Given this list of marker genes Apc2, Fbxl16, Psmd2, Hamp, Cpb2, Egfr, Ube2n, Cd81, Zdhhc2, Fbxo48, Psmd10, Trpc4ap, Pramel31, Rnf26, Ube3c, App, Tmem132a, Trib3, Chmp3, Psmb10, Cblb, Gtsf1, Chmp1b2, Nsf, Ube2h, Lonp1, Nkd1, Dcaf12, Ufsp2, Kcne2, Cenatac, Rmnd5b, Cdkn1b, Fbxo22, Derl1, Klhl25, Nploc4 (NCBI Gene Id 276977), Rnf111, Agbl4, Adam9, Znrf4, Mir196b, Amfr, Tlk2, Hectd3, Fbxo7, Nedd4 (NCBI Gene Id 639396), Slc9a1, Gtpbp1, Anapc5 (NCBI Gene Id 67965), Tmem67, Apoe, Zfp418, Ext1, Styx-ps, Oxa1l, Notch1, Agtpbp1, Mme, Cnot6l, Psmd1, Wfs1, Zpr1, Erlin1, Sec61b, Rnf133, Tnrc6a (NCBI Gene Id 76695), Psmb2, Pkd1 (polycystin 1, transient receptor potential channel interacting), Cd2ap, Slfn8, Trim67 (NCBI Gene Id 330863), Rnf13, Nkd2, Arih1, Hspa1a, Caprin1, Psmc1, Foxl2 (forkhead box L2), Pygm, Ecpas, Rchy1, Fbxw7, Sufu, Erap1, Pramel33, Hyal3, Cbfa2t3, Hexb, Gid8, Trib2, Dtx3l, Socs5, Oaz3, Psme3, Ptbp1, Sharpin, Gm11690, Anapc13, Ern1, Cdkn2a, Dlgap1, Ltn1, Sdf2l1, Ubxn8 (UBX domain protein 8), Slc17a9, 4930486L24Rik, Gclc (NCBI Gene Id 28039), Abhd13, Slc6a7, Cnot7, Gspt2, Psmd3, Calcr, Wipi2, Afg3l2, Efna1, Nop53, Dpp3, Pramel41, Pcbp2, Khsrp, Psap, Nupr1, Samd9l, Yme1l1, Cpeb3, Nudt16, Rnf187, Samd4, Fap, Stx5a, Exosc3, Ago3, Fbxl4, Psmc4, Dhx9, Rnaseh2b, Atg4b, Uba52, Snhg15, Vps4a, Bfar, Disc1, Pnrc1, Mirlet7c-1, N4bp1, Becn1, Ctsd, Rab12, Plekhn1, Ttc3, Fbxw4, Tmub2 (transmembrane and ubiquitin-like domain containing 2), Chmp7, Prr5l, Lsm14b, Sgsm3, Cnot8, Wnt5a, Grsf1, Rc3h1, Klhl42, Herpud1, Lnx1, Bag6 (BCL2-associated athanogene 6), Foxo1, Prpf19, Ivns1abp, Agap2, Atraid, Pramel6 (PRAME like 6), Cln3, Ldc1, Nrg1, Ubxn11, Fbxl9, Afg2b, Nrdc, Rnf11, Ppp1r3b, Mir144, Ubqln4, Nbas, Nfe2l2 (NCBI Gene Id 98874), A1cf, Tnf, Arrb1, Ubl4a, Ift80 (intraflagellar transport 80), Ascc2, Gna12, Tmem9, Sgta, Calr, Csde1, Hace1 (NCBI Gene Id 73291), Rnf121, Grn, Tent5d, Hipk2, Zar1, Pop1, Pygb, Svip, Rnf126, Slc6a17, Mgat3, Cdh1, Nedd4l, Rbm38, Znrf1, Dicer1, Ppp1cb, Dab2ip, Upf2, Ern2, Psmc3, Man1c1, Gsk3b, Ubxn2b, Apex1, Rnf6 (ring finger protein (C3H2C3 type) 6), Sumo2, Nr1d1, Skp1, Kbtbd12 (NCBI Gene Id 74589), Uba6, Fxr1, Apoc2, Mtrex, Lipa, Uchl1, Dnajc10, Ppp1r3e, Pramel25, Rmnd5a, Wwp2, Lsm7, Rffl, Ikbke, Rhbdd3, Tgfb1, Spsb3, Nsfl1c, Nub1, Lyplal1, Gm12610, Rad23b, Eri1, Ccin, Uvrag, Mettl1, Cyp51, Sgsh, Rpl11, Csdc2, Kctd17, Setmar, Calr3, Nhlrc3, Dvl1, Naf1, Adam8, Man1b1, Exosc6 (exosome component 6), Asb5, Nemf, Axin1, Kbtbd3, Mmp12, Tent4b (NCBI Gene Id 70570), Pramel37, Traf7, Fem1b (fem 1 homolog b), Hmgb1 (NCBI Gene Id 15289), Pramel13, Cop1, Cpa1, Herc4, Ctss (NCBI Gene Id 13040), Snx1, Fbxl22, Csnk2b, Usp7, Ube2l6, Trim31, Rdx, Fastkd3, Plk3, Wdr45, Abhd12, Anapc16, Psmc6, Laptm4b, Vps25, Ptpn23, Pramel55, Ythdf1, Malt1, Tbl1x, Rnf185, Pramel26, Trim45, Ube3b, Akirin2, Zfp598 (NCBI Gene Id 213753), Cdk5, Gata5, Atp13a2 (NCBI Gene Id 74772), Tent5a, Anapc10, Phkb, Cacul1, Cpn1, Gns, Arel1, Ybx2, Uba1y, Spopfm3, Edc4, Fgf2, Pramel42, Selenos, Azin2, Psme3ip1, Pcbp4, Clock, Ddi1, Cdk5rap3, Fbxo45, Ankrd9, Ddrgk1, Spop, Acr, Paip1, Fbxl18, Armc8, Sox17, Vegfa, Ddit3, Erlin2, Tspan5, St14, Rnf148, Mmp9, Etf1, Abca2, Vgll4, Gba1 (NCBI Gene Id 14466), Atg7, Man1a2, Isg20, Zfp36l3, Crbn, Igf2bp1, Psmb1, Boll, Cdc26, Keap1, Folh1, Zfp36, Zfp36l1, Fam83d, Pisd, Gga3, Idua, Pgpep1, E2f1, Ubxn7, Cul9 (cullin 9), Pdcl3, Pias4, Mmp2, Dnase1, Nudt16l1, Adrb1, Herc2, Klhdc10, Rybp, Trim72, Ube2a, Fam76b, Araf, Kctd5, Grin2c, Crebrf, Fbxw8, Fastkd1, Ceacam2, Wnt10b, Ube2j2, Det1, Pkp1, Rnf25, Snf8, Traf5, Timp1, Rnft1, Klhdc2, Lats1, Sqstm1, Siah1b, Trim32, Slc11a1, Tardbp, Trip12, Kctd10, Ssb, Exosc4, Rnaseh2a, Spopfm2, Dnajb12, Rbm24, Nqo1, Il17a, Derl3, Mkrn2, Trp53inp2, Map1a (microtubule-associated protein 1 A), Dtl, Psmb11, Lyve1, Ube2z, Scgb1a1, Sirt2, Psme4, Tmtc3, Isg15, Pcsk9, Ctsz, Rbm46, Serpinb1b, Pcid2, Oog1, Pramel11, Klhdc1 (NCBI Gene Id 271005), Oaz2, Cops3, Dis3l, Zc3h4, Gigyf2, Ripk1, Nedd8, Usp19, Ythdf3, Phb1, Aifm1, Aoah, Gpx1, Exosc5, Tob1, Smg8, Trim21, Csnk2a2, Klhl20, Cul4b, Marchf2, Kctd13, Mmp3, Ubqln2, Magoh, Usp26, Ap5z1, Senp1, Fbxl17, Trim28, Cln8, Tut4, Bag2, Ube4b, Ctsk, Anapc15, Zhx2, Ube2r2, Fastkd5, Dnajb2, Sh3rf2 (SH3 domain containing ring finger 2), Skic3, Adra1b, Bbs7, Tmem168, Nanos2, Aqp11, Asb1, Dcp1b, Ubxn4, Pramel48, Zc3h18, Casc3, Trnt1, Axin2, Rbm8a2, Ubd, Herc3, Smarcc1, Gdnf, Pramel38, Arrdc4, Psme1, Bnip3l, Lamp2, Pramel1, Siah3, Trim26, Lnpep, Sco1, Znrf3, Fbxo27, Enc1, Marchf7, Zer1, Klhl35, Anapc11, Os9, Arih2, Pnldc1, Rhbdd1, Snx3 (NCBI Gene Id 54198, sorting nexin 3), Psmd4, Cnot9, Dnd1, Clpp, Fxr2, Tdpoz4, Patl2, Zc3h12d, Snx5, Mmp14, Trim30a (tripartite motif-containing 30A), Snd1, Ubr2, Fbxo2, Ddx49, Rnps1, Gabarapl1, Qki, Serpine2, Nudt12, Rnf168, Pja1, Paqr3, Fyn, Spsb1, Arrb2, Gipc1, Mettl3, Sh3rf3, Klhl21, Neu2, Glmn, Dxo, Ins2, Uhrf1, Aurka, Trip4, Smurf1, Atg5, Trex2, Rnf7l, Pfkm, Klhl11, Pramel35, Psmd7, Rab7, Psma5, Pramel30, Stt3b (STT3, subunit of the oligosaccharyltransferase complex, homolog B (S. cerevisiae)), Chek2, Mmp20, Ctnnb1, Ago2, Chmp6, Asb2, Fbxl15, Atxn3, Fbxl12, Usp9x, Ipp, Pappa, Anxa2, Ube2k, Egf, Ctsj, Septin3, Pja2, Tdpoz2, Chmp4c, Rnf144b, Psmc5, Dda1, Ric1, Tut1, Rgp1, Ube2s, Dcaf1, Ctsh, Plaa, Spsb2, Uchl5, Sirt6, Stub1, Dcps, Rexo4, Klhl12, Il1b, Rnf149, Apc, Pnpt1, Oaz1, Nbdy, Pramel44, Ccar2, Azin1, Gzmb, Ankzf1, Psmb9, Pabir1, Ctsc, Edem2, Epha4, Trim9, Ascc3, Patl1, Ubr4, Tmem199 (NCBI Gene Id 97763), Fastkd2, Tent2, Hyal2, Apobec1, Wdr82, Dhx36, Ube2v2, Rhbdf1, Rnf166, Ecscr, Foxred2, Osbpl7, Xbp1, Hamp2, Nell1 (NEL-like 1), Trem2, Ins1, Ube2j1, Sec22b, Traf4, Sumo3, Rnf186, Ier3, Zcchc17, Casp12, Mapk8, Bnip3l-ps, Ctrb1, Rbm7, Xrn2, Rela, Ubr5, Fhit, Smad4, Tent5c, Ifng, Psmb3 (NCBI Gene Id 99155), Samd4b, Git1, Ube2l3, Chit1, Klhl23, Rnf115, Rnf216, Exog, Shh, Rbx1, L3mbtl3, Vps54, Il6, Klhl38, Usp25, Ddx5, Wdr77 (WD repeat domain 77), Fen1, Dazl, Mirlet7c-2, Plk1, Ttc5, Lin28a, Pan2, Trim39, Anapc15-ps, Ate1, Ntaq1, Grin2a, Tbx21, Btk, Oog4, Nanos1, Pum1, Rb1cc1, Dis3, Zp3r, Fbxo39, Usp44, Spsb4, Socs4, Rnf103, Lypla1, Trim38, Cul2, Pramel53, Ubl7, Hnrnpd, Ddb1, Hdac6, Hnrnpu, Cdc20b, Tspan17, Ark2c, Tcirg1, Pramel21, Fbxo44, Meioc, Rnf167, Klhl30, Slc6a8, Slfn9, Brinp1, Gpc3, Ogt, Anapc1, Cnot1, Otud7a, Slirp, Mlh1, Zc3h12a, Pramel7, Exosc8, Cirbp, Pcyox1l, Ppp1ca, Pglyrp3, Wipi1, Afg1l, Galns, Klhl41, Pnrc2, Ntan1, Psmd6, Nfe2l1, Rnf43, Hyal4, Maea, Pgm1, Cul3, Mdm2, Tbl1xr1, Uchl3, Gabarapl2, Smg5, Nccrp1, Taf9, Atg2a, Vip, Ubxn6, Timp2, Rnf123, Socs2, Wwtr1, Znrf2, Hnrnpc, Dnase2b, Ddi2, Vps36, Kctd21, Zc3hav1, Herc6, Gprasp1, Tmem129, Uba7, Upf3b (UPF3 regulator of nonsense transcripts homolog B (yeast)), Chmp4b, Pramel17, Chi3l1, Fbxw11, Fbxl20 (NCBI Gene Id 97750), Mfsd8, Ophn1, Lin28b, Tirap, Hnrnpab, Cemip, Hectd1, Dis3l2, Ctsq, Noct, Utp25, Dnase1l3, Zfp36l2, Cav1, Snx33, Tmem106b, Slfn2, Rnf125, Desi1, Naglu, Psmb8, Ang, Stab2, Notum, Ndufa13 (NADH:ubiquinone oxidoreductase subunit A13), Prkaca, Vps37d, Spata18, Tmf1, Tmem259, Lonp2 (NCBI Gene Id 66887), Ubxn10, Ngly1, Gan, Akt1, Usp13, Ccdc47, Psmb5, Ctso, Magohb, Xrn1, Cela1, Gusb, Ankib1, Ctsa, Klhdc3, Pabpc1, Hgsnat, Tbrg4, Cnot3, Oog2, Ube2dnl1, Htra2, Exosc1, Eif4a3l2, Fbxo4, Klhl29, Lrpprc, Rcn3, Trex1, Pum2, G6pc1, Mir196a-2, Trir, Hfe, Zmpste24, Abhd17c, Wdr26, Lsm4 (NCBI Gene Id 50783), Ufd1, Rnf20, Larp1, Pglyrp4, Spam1, Smg7, Filip1l, Ubb, Proca1, Pias1, Endog, Marchf6, Nrde2, Rlim, Ptk2, Dpp7, Dcst1, Kctd2, Ctsl, Fbxl2, Phka1, Secisbp2, Tnfaip3, Ang4, Atg3, Styx, Vps35, Capns1, Psmb6, Adamts13, Vps37b, Fbxw5 (F-box and WD-40 domain protein 5), Ube2u, Arrdc1, Rnf150, Lgmn, Capn10, Gfap, Pabpn1l, Dna2, Trib1, Hnrnpr (heterogeneous nuclear ribonucleoprotein R), Irak3, Hnrnpa0, Pramel22, Lsm1, Rnf130, Ube2dnl2, Exosc2, Rnasel, Pramel14, Rnf122, Ube2b, E330034G19Rik, Lyg2, Abhd17b, Hspa1b, Hyal6, Eif4enif1, Rpl23, Snx12, Chil3, Vcp (NCBI Gene Id 269523), Gspt1, Dab2, Psmf1, Asb9, Anapc4, Mettl16, Ndfip2, Piwil2, Adra2a, Cma1, Ppp1r3c (protein phosphatase 1, regulatory subunit 3C), Psmd11, Nln, Pbk, Rnf40, Park7, Bcas2, Usp38, Plg, Psma3, Piwil4, Igf2bp3, Pde12, Hsp90ab1, Rnf180 (ring finger protein 180), Rspry1, Prmt6, Mir196a-1, Prickle1, Hnf4aos, Snx25, Ubr3, Clu, Polr2g, Zfand2b, Rnf5, Gga1, Man1a, Rnf34, Pramel15, Dysf, Casp8, Hsp90aa1, Lrig2, Psma4, Rhobtb3, Smg6, Tesk1, Afg3l1, Trim40, Csnk1e, Fbxo17, Trim2, Pmp22, Fau (FAU ubiquitin like and ribosomal protein S30 fusion), Piwil1, Peli1, Rnf14, Ambra1, Rpl5, Lyset, Traf3ip2, Casp3, Pdlim2, Cts6, Pin1rt1, Commd1, Rgma (NCBI Gene Id 244058), Dnajc3, Tdpoz3, Mtpap, Sel1l2, Prkn, Chmp1a, Dennd3, Pcnp, Mtor, Ubr1, Ambp, Ncbp2, Dcp1a, Vps37a, Fem1a, Psma8, Pan3, Eif2ak3, Bcap31, Ctsw, Trim24, Dmac2, Serpinb1a, Vim, Ubc, Ccnf, Srsf1, Pramel20, Rnf7, Prep, Pramel12, Cma2, Kif16b, Npm1, Skp2, Gas5, Klhl15 (kelch-like 15), Psma2, Wdr91, Ids, Proc, Mvb12a, Calr4, Umod, Nhlrc1, Ctif, Elob, Gzmn, Igf2bp2, Rock2, Smg1, Get4, Socs7, Pramel24, Wdr45b, Kbtbd6, Birc2, Il33, Rnft2, Mir466l, Nanos3, Tdpoz9, Dffa, Klhl24, Ubap1, Aup1, Erlec1, Phkg2, Pramel36, Cela2a, Map3k1, Mus81, Mov10, Nrros, Cbl, Lamp3, Jkamp, Hecw2, Taf15, Chfr, Dnase1l2, Eloc, Ppp1r11, Fbxl13, Pramel45, Pramel29, Nudt15, Nsun4, Ttc36, Cdc16, Cdc34, Thrap3, Appbp2, Vps11, Pglyrp1, Saysd1, Psme2, Tspan15, Adcy10, Cts7, Usp8, Psma6, Rbck1, Tsg101, Uba1, Chmp2a, Eif4a3 (eukaryotic translation initiation factor 4A3), Pramel27, Mad2l2, Rps27a, Adam10, Ubqln3, Zranb1 (NCBI Gene Id 77556), H13, Pramel16, Chmp5, Rnaset2b, Dbr1, Ubap1l, Msn, Rnaseh2c, Gid4 (NCBI Gene Id 66771), Mylip, Atg2b, Hsp90b1, Chil6, Ldlr, Skic8, Ubqln5, Elavl1, Ezr, Tdpoz5, Psmb7, Kbtbd7, Slfn14, Sidt2, Rilp, Alad, Syvn1, Carhsp1, Lsm6, Manba, Mtmr2 (myotubularin related protein 2), Anks1, Mmp8, Itch, Zswim8 (zinc finger SWIM-type containing 8), Arsb, Traf2, Fbxo31, Mta1, Xpo1, Cul5, Pacsin3, Nlrp1b, Fbxl6, Lrrk2, Rnf19a, Ovgp1, Sh3glb1, Psmd8, Capn1, Oog3, Trf, Fem1c, Furin, Zyg11b, Liat1, Lyg1, Edc3, Rnf139, Pramel19, Usp28, Fbxo10, Rnf213, Cacng7, Ube2srt, Anapc7, Gpr108, Ppp1r3d, Cnot6, Snx9, Flna, Fmn2, Bag5, Cul1, Hbs1l, Tnfaip1, Snca, Csnk1a1, Fbxl14, Dact1 (dishevelled-binding antagonist of beta-catenin 1), Larp4b, Gabarap, Ptpn3, Igfbp3, Hspbp1, Faf1 (NCBI Gene Id 99976), Wwp1, Atm, Hecw1, Rad23a, Dpp4, Nsun2, Mapk15, Pramel60, C4bp, Ncbp1, Tnfsf12, Prkcg, Ppt1, Dnajb9, Klhl1, Rnf114, Smg9, Pramex1, Syncrip (synaptotagmin binding, cytoplasmic RNA interacting protein), Cblc, Cdc23, Tpp1, Vps28, Rnf4, Fto, Dkc1, Rbx1-ps, Cst3, Tollip, Chmp1b, Gtpbp2 (NCBI Gene Id 56055), Parn, Chmp2b, Glb1, Asb11, Phax, Gzmc, Mgam, Cts8, Rnf145, Cemip2, F8a, Oas2, Faf2, Ube2d2a, Irgq, Pramel43, Ago4, Bmal1, Btg2, Amer1, Wac, Nmnat1, Pml (promyelocytic leukemia), Nlrp5, Dnase2a, Mycbp2, Ercc8, Celf1, Hmmr, Elavl4, Mdm4, Sh3bgrl (SH3-binding domain glutamic acid-rich protein like), Ube3d, Tmub1, Ccdc115, Ube4a, Sh3d19, Trim13, Tut7, Klhl6, Ctsm, Oma1, Sirt1, Casp7, Pmaip1, Mapk9, Ago1 (NCBI Gene Id 286948), Alkbh5, Hexa, Midn, Spg11, Ubqlnl, Ndfip1, Usp5, Siah2, Qrich2, Edem1, Pin1, Clgn, Ybx1, Upf3a, Psma7, Plk2, Usp22, Pabpc4, Pramel18, Usp14, Ptpn1 (NCBI Gene Id 19246), Pramel40, Abhd17a, Wdr81, Rbm47, Eif2a, Sf3b3, Ube2g2, Chia1, Bnip3, Rnf217, Egln2, Pglyrp2, Gpld1, Cnot2, Trim58, Pramel46, Skic2, Sox9, Pcyox1, Mrto4 (NCBI Gene Id 69902), Csnk2a1, Blvra, Psen2, Cnot10, Vps13a, Pkp3, Cul4a, Tent4a, Rnf41, Trim71, Ube2g1, Fbxl19, Atp5if1, Lpcat1, Ythdf2, Sgms1os1, Mad2l1, Pygl, Gaa, Ecrg4, Smad3 (NCBI Gene Id 17127), Capn3, Ubac2, Spopl, Rnf170, Ufl1, Zc3h14, Hmgcr, Rbm33, Rnf144a, Rnaset2a (ribonuclease T2A), Fbxo8, Rnf8, Rock1, Socs6, Rnf19b, Ube2c, Gzma, Nicol1, Rnf215, Atg12 (NCBI Gene Id 67526), Dcaf11, Mettl14, Rbbp6, Klhl3 (NCBI Gene Id 639966), Tnrc6b, Ceacam1, Cast, Foxf2, Kbtbd8, Sh3rf1, Becn2, Dhx34, Ubqln1, Pramel5, Mapkapk2, Vps4b, Nudt16l2, Fbxo6, Lrp1, Phf20l1, Clpx, Adamts7, Bap1, Ube2w, Tgfb1i1, Il10, Ppp2cb, Exosc10, Laptm5, Nos2, Tmem126a, Pramel23, P2rx7, Rack1, Capn2, Ubxn2a, Siah1a, Adgrb1, Smurf2, Klhl28, Stam, Cdc27, Klhl5, Fastk, Pttg1ip, Neu4, Tdpoz8, Gsk3a, Cln6, Fbxo11, Edem3, Apob, Cul7 (cullin 7), Fbxo43, Ctsb, Synpo2, Pramel32, Fbxo38, Anapc2, Ubxn1, Zcchc7, Fbxl7 (NCBI Gene Id 448987), Fbh1, Csnk1d, Rbm10, Rgn, Tent5b, Lypla2, Mib1, Eif4a3l1, Timp3, Agap3, Clec16a, Myd88, Otud7b, Trim3 (NCBI Gene Id 55992), Kif14, Lsm2, Klhl2, Ctsll3, Lonrf2 (LON peptidase N-terminal domain and ring finger 2), Phkg1, Kat5, Mmp13, Topors, Psma1, Cd44 (CD44 antigen), Bax, Cnot4, Arid5a, Mir451b, Ppp2ca, Klhl40, Fem1al, Fbxl5, Eif3e, Rnf10, Hspa8, Exosc7, Ppp2r3a, Klhl8, Exosc9, Rpgr, Ppp2r5c, Lrsam1, Uchl4, Fbxo9, Vhl, Hsf1, Brf1, Trdmt1, Stbd1, Epm2a, Fbxo3, Ctbs, Trim63, Tiparp, Caml, Wnt1, Klhl18, Gpc1, Klk4, Pithd1, Canx, Dnase1l1, Timp4, Lsm5, Dnaaf4, Dtx4, Sumo1, Pym1, Odc1, Sel1l, Huwe1, Angel2, Tnrc6c, Pramel28, Eif3h, Rbm8a, Fbxl3, Kcmf1, Klhl10, Ide, Dcaf13, Ccdc22, Otud5, Mcpt9, Ube2d1, Rps7, Hyal1 (hyaluronoglucosaminidase 1), Rnf146, Ctsf, Hspa5, Tpp2, Mirlet7b, Pik3r4, Zfand2a, Gm13040, Gja1, Tor1a, Mir451a, Mir7578, Klhl4, Ube2d2b, Abhd10, Sorl1, BC051665, Btrc, Psmc2, Fzr1, Dcp2, Fmr1, Cts3, Psen1, Epg5, Sec61bl, Ark2n, Pramel51, Lrrc75a, Cdc20 (cell division cycle 20), Ankrd11, Rnf128, Pramel47, Pten, Supv3l1, Mtm1, Agl, Upf1, Mex3d, Klhl17, Ptk2b, Cdc34b, Ctsr, Tdpoz1, Rida, Adamts12, Rc3h2, Kbtbd2, Klhl22, Kctd6, Pelo, Amn1, Psmb4, Rybp-ps, Hpse, Ube3a (ubiquitin protein ligase E3A), Rnaseh1, Cidea, Brsk2, Ube2d3, Tnfrsf1b, Derl2, Fus, Pdcd6ip, Trim25, Chil4, Rnf26rt, Vps37c, Psmd14, Psmd13, Fbxo24, Hyal5, Apaf1, Pgm2, Tmx1, Dedd, Yod1, Klhl7, Il17ra, Chil5, Dffb, here is a description of the gene set: Mouse Gene Set: GOBP_MACROMOLECULE_CATABOLIC_PROCESS species: Mus musculus The chemical reactions and pathways resulting in the breakdown of a macromolecule, any molecule of high relative molecular mass, the structure of which essentially comprises the multiple repetition of units derived, actually or conceptually, from molecules of low relative molecular mass.